The following is a description of a gene set: Catalysis of the reaction: benzaldehyde + NAD+ + H2O = benzoate + NADH + H+. species: Mus musculus Mouse Gene Set: GOMF_BENZALDEHYDE_DEHYDROGENASE_NADPLUS_ACTIVITY, and this is the list of marker genes: Aldh3b1, Aldh1a7 (aldehyde dehydrogenase family 1, subfamily A7), Aldh3a1, Aldh1a1, Adh4 (NCBI Gene Id 26876)